The following is a description of a gene set: from publication Cairo S, Armengol C, De Reyniès A, Wei Y, Thomas E, Renard CA, Goga A, Balakrishnan A, Semeraro M, Gresh L, Pontoglio M, Strick-Marchand H, Levillayer F, Nouet Y, Rickman D, Gauthier F, Branchereau S, Brugières L, Laithier V, Bouvier R, Boman F, Basso G, Michiels JF, Hofman P, Arbez-Gindre F, Jouan H, Rousselet-Chapeau MC, Berrebi D, Marcellin L, Plenat F, Zachar D, Joubert M, Selves J, Pasquier D, Bioulac-Sage P, Grotzer M, Childs M, Fabre M, Buendia MA (PMID 19061838) species: Homo sapiens Human Gene Set: CAIRO_HEPATOBLASTOMA_DN Hepatoblastoma, the most common pediatric liver cancer, is tightly linked to excessive Wnt/beta-catenin signaling. Here, we used microarray analysis to identify two tumor subclasses resembling distinct phases of liver development and a discriminating 16-gene signature. beta-catenin activated different transcriptional programs in the two tumor types, with distinctive expression of hepatic stem/progenitor markers in immature tumors. This highly proliferating subclass was typified by gains of chromosomes 8q and 2p and upregulated Myc signaling. Myc-induced hepatoblastoma-like tumors in mice strikingly resembled the human immature subtype, and Myc downregulation in hepatoblastoma cells impaired tumorigenesis in vivo. Remarkably, the 16-gene signature discriminated invasive and metastatic hepatoblastomas and predicted prognosis with high accuracy. Genes down-regulated in hepatoblastoma samples compared to normal liver tissue., and this is the list of marker genes: FBP1, SDHB, MAP3K5, XDH, C1R, ALAS1, SLC20A1, RETREG1, ACSL1, CYP2C18, FXYD1, GAREM1 (GRB2 associated regulator of MAPK1 subtype 1, NCBI Gene Id 64762), LPA, EEIG1, DHRS1, PLAAT3, SIGIRR, SDS, C1RL, MAP2K3, GPD1, NR1I3, GPLD1, HGD, SLC43A3, CLEC1B, TMPRSS2, SLC27A5, STAB1, IL1RAP, SLC46A3, TENT5A, HPX, C9, SLC22A1, RIDA, BMERB1 (bMERB domain containing 1), SHBG, PCK2, PXMP2, NFIL3, FAAH, ALDOB, PAPSS2, ABAT, CXCL14, TRIB1, FAHD2A (NCBI Gene Id 90363), FOXO1, HP, ACAT1, SERPINE1, HPGD, CYP2B7P, EHD3, SYT17, SLC27A2, CA2, HSD17B6, HGFAC, HAO2, GCH1, VNN1, CYP2B6, MGLL, CYP2D6, STARD5, ETNPPL, CYP39A1, CETP, GSTT2, GYS2, STAB2, PFKFB1, HAL, GLS2 (glutaminase 2), OGDHL, ZG16, INHBB, IGFALS, MASP2, ABHD2, PXDC1, TMEM131L, C8G, C8A, FCGR2B, GCDH, GRAMD4, MAP3K14, INSIG1, CREM, ACACB, LPIN2, EXT1, RND3, CDC37L1, DHTKD1, ADH1C, CYP2C8, ACADM, ABCB11, IGFBP3, UGT1A8, CHST7, TSPYL5, APOF, EPHA2, HABP2, CD14, TDO2, TFR2, ITIH4, ACAA1, C6, CYP4F3, CRHBP (corticotropin releasing hormone binding protein), CBS, CRP, GNMT, SLC1A1, PZP, SLC3A1, PPP1R1A, MMUT, SORL1, CYP2C19, AASS, NQO2, PON1, CFP, FETUB, ENDOG, ZGPAT, TSKU (NCBI Gene Id 25987), PPARGC1A, MAN1C1, RNF125, SARDH, PDLIM5, GCGR, CPEB3, NR1I2, MCL1 (NCBI Gene Id 4170), CYP4F11, LEPR, GOT1, ST3GAL6, MFAP3L, DCPS, ZFAND5, GRAMD1C, SRD5A1, PRODH, GLYAT, ACAA2, SRD5A2, AGPAT2, HAAO, LONP2, UGP2, CYP1A2, ETS2, MPC1, FCN3, CYP2A6, SLC10A1, GREM2, SHMT1, GBA3, INPP1, LYVE1, NNT, CDA, OSBPL1A, NAMPT, PLG, AQP3, SAA4, SKAP1, GPR88, PCK1, ACADL, AGXT, ADK, CTH, KLF6, NDRG2, F9, AKR1D1, CLEC4M, ANXA10, GADD45G (NCBI Gene Id 23575), ENO3, LCAT, IL13RA2, SUCLG2, CYP2J2, ANG, ACADS, ADM, RAB27A, VIPR1, MARCO, PTS, SLC25A15, ASL, CYP26A1, DHODH, ALPL, ENSG00000240291, ANO1, SLC22A7, CYP3A5, ABLIM3 (NCBI Gene Id 22885), ETFDH, DDT, ARHGEF26 (Rho guanine nucleotide exchange factor 26), GSTZ1, MAT1A, SOCS2, AGL, HAGH (NCBI Gene Id 3029), NAT2, IGF1, SLC37A4, GHR, MYOM1, ANGPTL4, ID2, KDM8, BBOX1, ZC3H12A, SLPI, ECM1 (NCBI Gene Id 1893), CTPS1, AZGP1, FCN2, KCND3, RDH16, SERPINB8, SCP2, MT1M, HRG, PEMT, PTH1R, CFHR4, RCL1, N4BP2L1, IL4R, C8B, GNE, FAM149A, SERPING1, ASS1, VSIG4, CPT2, TENM1, DAO, CIDEB, NNMT, DNASE1L3 (deoxyribonuclease 1L3), PRG4, SLC38A4, F11, ADGRA3, NRG1, KMO